Given this list of marker genes KBTBD2, MRPL9, RAN, SPP1, PTDSS1, DOLK, GPSM2, FBL (fibrillarin), EIF6, BORA, LRP8, RAB4B, H2AZ1, POFUT1, MRPL17, ERI1, PLAU, RRM1, ICA1, ALG1, LDHB, TRUB2, WDR75, DDX39B, NOB1, HM13, PSMB1, TKT, MELK, RFC5, PDK3, CHCHD2, ADGRG1, MDC1, PDCD6, ATIC, SRSF2, CSTF1, LST1, MTHFD2, SOD2 (NCBI Gene Id 79099), CD46, MCM5, NEBL (nebulette), TIMP1, AURKA, SH3GL1, HELLS, WDR74, MCM2 (minichromosome maintenance complex component 2), GTF2F2, PSMB7, NUSAP1, AMPD3, MRPL3, DUSP18, GTF3A, TALDO1, CKS2, SOX9, HOXB5, CAMSAP1, PLCB4, TMEM97 (NCBI Gene Id 27346), DPM1, TCF7, POLQ, METTL2B, EPRS1, SYAP1, KARS1, CNBP, TGFBI, IRAK1, HNRNPA2B1, BACE2, CCDC191, UBD, AZGP1, PRDX1, CDK1 (cyclin dependent kinase 1), COL4A1, SPATA13, USP7, FBXO11, THY1, OSER1, PSMB3, MBTPS2, TRAF5, SRSF1, POLR2D, EIF4B, CDCA7, POLR1D, PSMA2, SEPHS1, UBE2N, MRGBP, MCM4, PABPC3, SSRP1, THEM6, PCNA, PTCD3, EEF1E1, SHISA5, UBR4, VBP1, THOC3, ATP6AP2, PPIA, DRG1, TPI1, RCC1, PKM, CEP57L1, PDCD2L, ETV4, S100A14, SFT2D3, NOL8, CSNK1E, FDFT1, DDX39A, GTPBP10, PLAAT3, EMC8, RCN1, ACBD6, CDC45, DCAF7, HSPA9, GDF15, TBCE, IFRD1, SRP72 (NCBI Gene Id 6731), SERPINB5, HSPE1, GEMIN6, URI1, EPHB2, CTSB, MACROH2A1, PLK1, HSPA4, MTHFD1 (methylenetetrahydrofolate dehydrogenase, cyclohydrolase and formyltetrahydrofolate synthetase 1), CDC25B, PDXK, COPS8, TFB1M, HILPDA, RLIM, ZMYND8 (zinc finger MYND-type containing 8), L1CAM, NONO, PRKDC, POMP, ETS2, PNPT1, CCDC85B, NOP56, ITGB5, EXOC2, CCNB1, SSB, OLA1, MKLN1, TRAP1 (NCBI Gene Id 51721), GARS1, TARS1, HNRNPA1, SPARC, ANXA5, PA2G4, XRN2, GCSH, SLC12A2, GYG2, FERMT1, CD44, ABCB8, PERP, DPY19L1, SAP18, KIF23, VEGFA, KNTC1, RTF2, GCLC, RHEB, AAMP, ZNF84, DDX1, ENG, DHX9, RBM26, POLD2, NPM1, EIF3B, UTP11, FAM210B, HNRNPK, PXDN, ZNG1B, DGAT2, SMPD4, NQO2, DDIT4 (NCBI Gene Id 54541), HJURP, BPHL, CARHSP1, PSMG1 (NCBI Gene Id 8624), HMGB1, NIP7, DHX8, DNTTIP1, KPNA3, RFC2, CDK7, AARS1, SET, PRDX4, PAFAH1B3, METTL5, NAA10, NDUFAF7, SNRPB, SKA3, GLO1, GSK3B, PFDN2, RMI2, PPA1, EFTUD2, FXYD5, NIT2, RRM2, LAPTM4B, CFB, ZFAND1, MARS1, CDC6, ABCF1, MCM3, PMPCB, EIF3E, MAGED2, PTPN12 (protein tyrosine phosphatase non-receptor type 12), PSMA3, AHCY (adenosylhomocysteinase), SYNCRIP, CCT7, EIF2S2, INTS7, MYC, EIF4A1, CCDC92, DDX27, LYAR, CCT5, DAP3, NMI, DNAJC2, PSMD14, IFITM1, PNPO (pyridoxamine 5'-phosphate oxidase), DNAJA3, HMGB2, PSMA1, LAMP1, NSMCE2, ZDHHC9, C4BPB, TMSB4Y, USP9X, VKORC1L1, DEF8, LY6E, TIMELESS, CCT8, TTPAL, RTKN, MCM7, LDHA, HNRNPD, TGDS, METTL3, MLST8, PSMD4, here is a description of the gene set: species: Homo sapiens Up-regulated genes in both rectal and colon carcinoma compared to normal mucosa samples. Human Gene Set: GRADE_COLON_AND_RECTAL_CANCER_UP To characterize patterns of global transcriptional deregulation in primary colon carcinomas, we did gene expression profiling of 73 tumors using oligonucleotide microarrays. For 30 of the tumors, expression profiles were compared with those from matched normal mucosa samples. We identified a set of genes with highly significant deregulation between tumors and mucosa samples (P < 1e-7). A significant proportion of these genes mapped to chromosome 20 (P = 0.01). Seventeen genes had a >5-fold average expression difference between normal colon mucosa and carcinomas, including up-regulation of MYC and of HMGA1, a putative oncogene. Furthermore, we identified genes that were significantly differentially expressed between lymph node-negative and lymph node-positive tumors (P < 0.001), the functional annotation of which revealed a preponderance of genes that play a role in cellular immune response and surveillance. The microarray-derived gene expression levels of 20 deregulated genes were validated using quantitative real-time reverse transcription-PCR in >40 tumor and normal mucosa samples with good concordance between the techniques. Finally, we established a relationship between specific genomic imbalances, which were mapped for 32 of the analyzed colon tumors by comparative genomic hybridization, and alterations of global transcriptional activity. Previously, we had conducted a similar analysis of primary rectal carcinomas. The systematic comparison of colon and rectal carcinomas revealed a significant overlap of genomic imbalances and transcriptional deregulation, including activation of the Wnt/beta-catenin signaling cascade, suggesting similar pathogenic pathways. from publication Grade M, Hörmann P, Becker S, Hummon AB, Wangsa D, Varma S, Simon R, Liersch T, Becker H, Difilippantonio MJ, Ghadimi BM, Ried T (PMID 17210682)